Given this list of marker genes NFIB, CCND2, PHF8, UBQLN2, YPEL5, COQ2, KLHL15, SNRNP40, SEC22B, NLRP9, SNX14, USP25, YY1, MYEF2, ACKR4, TCEAL4, RBM11, RWDD2A (NCBI Gene Id 112611), GABRR2, PFKFB2, SIN3A, EBF3, CAPRIN1, ALDH1A2, NGLY1, LEF1, FGD4, CBLB, PCDH19, IRAK1BP1, ITSN2, SLC45A3, CAPN2, ZFHX4, MIER1, SNX4, here is a description of the gene set: species: Homo sapiens from publication Chen Y, Wang X (PMID 31504780) Genes predicted to be targets of miRBase v22 microRNA hsa-miR-621 in miRDB v6.0 with MirTarget v4 prediction scores > 80 (high confidence targets). Human Gene Set: MIR621